Given this list of marker genes MIR185, ROCK2, SPRY2, MIR361, MIR495, CNMD, HGS, ADGRB2, TAFA5 (NCBI Gene Id 25817), SEMA4A, ANGPTL7, ADGRB1, QKI, NPPB, HOXA5, PLK2, CTNND1, APOH, SPINK5, NAXE, MIR377, STARD13, SPARC, THBS4 (thrombospondin 4), ECSCR, MIR885, ATF2, MIR29C, DCN, MIR34B, PIK3CB, MECP2, MIR222, MIR640, EPN1, MIR221, DAB2IP, MIR375, SERPINE1, COL4A2, ANGPT4, MIR214, GDF2 (growth differentiation factor 2), GHRL, ROCK1, MIR10A, FOXC1, MIR146A, ALOX5, MIR503, MIR30E, MIR20A, PGK1, VASH1, NF1, TNMD, MIR193A, AGO1, ATP2B4, MIR19A, MIR424, TIE1, SULF1, FASLG, CREB3L1, PML, E2F2 (NCBI Gene Id 1870), MIR101-1, GTF2I, MIR145, TGFB2, PTPRM, TNF, THBS2, STAT1, MIR15B, CCN6, KLF4, CXCL10, ISM1, SERPINF1, CXCR3, EPN2, MIR329-1, MIR200B, EFNA3, ADGRB3, MIR15A (NCBI Gene Id 406948), MIR505, CCR2, PTPN6, KRIT1, KLF2, MIR492, MIR1298 (microRNA 1298), CTNNB1, YJEFN3 (NCBI Gene Id 374887), MIR34C, NPR1, MIR21, SLC12A2, MIR212, CD36, SHC1, CD160, MIR125B1, STAB1, RELA, EMILIN1, HLA-G, COL4A3, THBS1, TEK, MIR16-1, MIR92A1, MIR494, CLDN5, MINAR1, MIR20B, EPHA2, MIR30C1 (microRNA 30c-1), MIR30B, RGCC, ANGPT2, WNT4, HHEX, MIR24-1, MIR18A, MIR217, HSPG2, AMOT, CX3CR1, SEMA6A, MIR939, PRL, SARS1, MIR199B, GPR4, GADD45A, FBLN5, MIR137, PDE3B, FOXJ2, IL17F, PF4, SPRED1, MIR34A, ZNF354C (zinc finger protein 354C), FOXO4, PPARG, MIR205, HRG, MIR17 (microRNA 17), MIR487B, MIR106B, SYNJ2BP, MIR138-1, ADAMTS1 (ADAM metallopeptidase with thrombospondin type 1 motif 1), MIR29A, FYN, ABCC8, SEMA3E, MIR125A, MIR143, ADAMTS9, KLK3, OPTC, here is a description of the gene set: species: Homo sapiens Any process that stops, prevents or reduces the frequency, rate or extent of vasculature development. Human Gene Set: GOBP_NEGATIVE_REGULATION_OF_VASCULATURE_DEVELOPMENT